Given this list of marker genes Hgf, Gba1, Csk, Sirpa, Elf4 (E74 like ETS transcription factor 4), Cd24a, Flt3, Gas6, Ghsr, Tlr4, Bank1, Slamf1, Arrb1, Nckap1l, Aqp4, Nlrx1, Cd200r1, Zc3h12a, Trim30a, Cd84, Irak3, C5ar2, Prg4, Nr1h4, Foxj1 (forkhead box J1), Chrna7, Ptpn6, Klf2, Il10, Nmbr, Lilrb4a, Bpi, Ghrl, Nlrc3, Syt11, Cd200, Il36rn, Tnf, Tnfrsf1a, Nmb, Muc16, Lilrb4b, Rabgef1, Havcr2, Nlrp12, Inpp5d, Ptpn22, Tnfaip3, C1qtnf3, Arrb2, Il27ra, Selenos, Foxp3, Socs5, here is a description of the gene set: studied in species Mus musculus Any process that stops, prevents, or reduces the frequency, rate, or extent of interleukin-6 production. Mouse Gene Set: GOBP_NEGATIVE_REGULATION_OF_INTERLEUKIN_6_PRODUCTION